The following is a description of a gene set: Human Gene Set: GOBP_SOMATIC_STEM_CELL_DIVISION The self-renewing division of a somatic stem cell, a stem cell that can give rise to cell types of the body other than those of the germ-line. studied in species Homo sapiens, and this is the list of marker genes: VANGL2, HOXB4, FUT9, ZFP36L2, TGFB2, FUT10, WNT7A (NCBI Gene Id 7476), CDKN2A, FZD7, WNT3A (NCBI Gene Id 89780), MIR145, BMI1, NOTCH1, LBH